The following is a description of a gene set: Mouse Gene Set: GOBP_EXONUCLEOLYTIC_TRIMMING_TO_GENERATE_MATURE_3_END_OF_5_8S_RRNA_FROM_TRICISTRONIC_RRNA_TRANSCRIPT_SSU_RRNA_5_8S_RRNA_LSU_RRNA Exonucleolytic digestion of a pre-rRNA molecule to generate the mature 3'-end of a 5.8S rRNA molecule derived from an originally tricistronic pre-rRNA transcript that contained the Small Subunit (SSU) rRNA, the 5.8S rRNA, and the Large Subunit (LSU) rRNA in that order from 5' to 3' along the primary transcript. species: Mus musculus, and this is the list of marker genes: Exosc9, Exosc10, Exosc3, Exosc2, Eri1, Exosc7, Exosc8